Given this list of marker genes Ercc6, Lif, Ifng, Ifnb1, Ret, here is a description of the gene set: studied in species Mus musculus Any process that activates or increases the frequency, rate or extent of the phosphorylation of a serine residue of a STAT (Signal Transducer and Activator of Transcription) protein. Mouse Gene Set: GOBP_POSITIVE_REGULATION_OF_PEPTIDYL_SERINE_PHOSPHORYLATION_OF_STAT_PROTEIN